Given this list of marker genes ATF1, BRPF3 (bromodomain and PHD finger containing 3), E2F8, AGER, GLI2, SMARCA5, STN1, ATAD5, ENDOG, FAF1, INO80, DBF4B, CDK1, SSBP1, CDT1, WEE1, FGFR1, PTK6, KAT7, KCTD13, GLI1, CDC7, ATRX, TNFAIP1, CTC1, CDK2, E2F7, CACYBP, CDKN1A, DHX9, CIZ1, DNA2, BAZ1A, CDKN1B, PCNA, CDC25A, NPM2, UCN, EREG, DBF4, WIZ, EGFR, here is a description of the gene set: Human Gene Set: GOBP_POSITIVE_REGULATION_OF_DNA_REPLICATION Any process that activates or increases the frequency, rate or extent of DNA replication. species: Homo sapiens